Given this list of marker genes KAT5, PIK3C3, SUV39H1, TBL2, ATF4, SESN1, ASNS, SESN2, SIRT1, ATG14, SH3GLB1, NUAK2, HIGD1A, YWHAZ, PLIN3, HSPA5 (NCBI Gene Id 3309), BECN1, EIF2AK3, PRKAG2, KPTN, ITFG2, PLIN2, SLC2A1, ZC3H12A, IFI16, CHKA, MTMR3, PICK1, YWHAG, MYBBP1A, XBP1, SLC7A5, SZT2, SESN3, HNRNPA1, PRKAG3, KICS2, BHLHA15 (basic helix-loop-helix family member a15), PRKAA2, CPEB4, NFE2L2, TP53, PIK3R4, FOXO3, PMAIP1, PRKAA1, BCL2, PRKAG1 (NCBI Gene Id 5571), UPP1, RRP8, here is a description of the gene set: Any process that results in a change in state or activity of a cell (in terms of movement, secretion, enzyme production, gene expression, etc.) as a result of deprivation of glucose. Human Gene Set: GOBP_CELLULAR_RESPONSE_TO_GLUCOSE_STARVATION studied in species Homo sapiens